Given this list of marker genes GRHL1, JUP, DSC1, SNAI2, PERP (NCBI Gene Id 64065), PKP2, PKP3, DSG2, CDH1, KPRP, PKP1, DSG3, PRKCA, DSP, NECTIN1, here is a description of the gene set: Human Gene Set: GOBP_DESMOSOME_ORGANIZATION A process that is carried out at the cellular level which results in the assembly, arrangement of constituent parts, or disassembly of a desmosome. A desmosome is a patch-like intercellular junction found in vertebrate tissues, consisting of parallel zones of two cell membranes, separated by an space of 25-35 nm, and having dense fibrillar plaques in the subjacent cytoplasm. studied in species Homo sapiens